Given this list of marker genes WBP2, ICOSLG, CYGB, MARCHF6, ACACA, NBEAL2, AUP1, RRS1-DT, VPS11, STON1, POLR2A, TRIM11, USP40, ZNF746, APLP2, PPP1R9B, BLTP3A, NKTR, SMYD5, ARID5A, CENPT, TENT5A, PDLIM1, WDR31, PHOX2B, WHAMM, GORASP1, YKT6, ARAF (NCBI Gene Id 369), PREX1, LINC00852, DOCK2, ARHGEF28, KRT18, SIK3, ATG2B, SERPINE1, EIF3B, KIAA1614, PRSS58, OR3A1, GP6, OMG, PWWP2B, MRPL45P2, MCHR1, ZER1, ADCY4, TRIM41, MAN2A2, FBXL12, FMNL1, CAPN1, MAPKAPK2, CTSK, HOMER2, TMEM94, AFAP1L2, SMOX, ABL1, KCNAB2, PTPN18, PLEKHS1 (pleckstrin homology domain containing S1), MAN2C1, TSPAN33, PIP5K1C, PARGP1, BMF, SERPINB6, DCTN1, ACCS, ANKRD10, MAP1B, TOE1, SUPT5H, PPP6R1, ZBTB34, NAA15, HGS, VIPR1, SNX29, PCDH11Y, NRDC, ATAD5, RIN3, MAPKAP1 (NCBI Gene Id 79182), ULK1, PJVK, NXF1, ATF4, SMAD7, XPNPEP1, PAN3, SUPV3L1, PCLO, DDX24, RP9, TGFB1, PARP6, ATF5, DCAF1, SLC11A2, NEK3, LEPROT, PNISR, MED27, CCNT1, WDR91, LINC01426, ZNF317, SMG7, PML, IP6K2, PIK3R5, MYO19, DNAJC4, PHLPP1, SQSTM1, ATG9A, TMEM198B, AGPAT1, IBA57, PITPNM1, KMT5A, INF2, RNF103, LDB1, GMEB2, USP5, ALKBH5, LINC02915, BAP1, MDM4, CTNNBIP1, SPNS1, STUB1, ARHGAP4, GARS1-DT, PEDS1, TENT4A, GATA2-AS1, GLTP, TEX36, GRIK1-AS1, UBAP2L, AKAP8, TLE3, CARM1, DIP2B, CUL9, SFPQ (NCBI Gene Id 6421), RPRD1B, MNS1, AP1G1, TPM2, ACTB, SEC31B (SEC31 homolog B, COPII coat complex component), UBE2E3, ZNF185, CORO7, OR2F2, GCNT7, FAM133B, ZNF34, ZXDB, RNF126, MAP4K4, FGD6, ACAP3, TUG1, MAP3K3, C6orf136, MGLL, SMR3B, USP36, FAM238B, SND1-IT1, GABBR1, ENG, PER1, WRN, AJUBA, BMAL1, CYP4F8, SRSF1, SGSH, NAB2, TBC1D5, LINC01089, TNFRSF1B, STXBP2, here is a description of the gene set: Genes up-regulated in comparison of unstimulated peripheral blood mononuclear cells (PBMC) 1 day after stimulation with YF17D vaccine versus PBMC 21 days after the stimulation. Human Gene Set: GSE13485_DAY1_VS_DAY21_YF17D_VACCINE_PBMC_UP The immune responses generated by YF-17D by profiling genes in 25 vaccine recipients were accessed at days 1, 3, 7, and 21 post-vaccination compared to pre-vaccination in PBMCs. The immune responses generated by YF-17D by profiling genes in 25 vaccine recipients were accessed at days 1, 3, 7, and 21 post-vaccination compared to pre-vaccination in PBMCs. from publication Querec TD, Akondy RS, Lee EK, Cao W, Nakaya HI, Teuwen D, Pirani A, Gernert K, Deng J, Marzolf B, Kennedy K, Wu H, Bennouna S, Oluoch H, Miller J, Vencio RZ, Mulligan M, Aderem A, Ahmed R, Pulendran B (PMID 19029902) species: Homo sapiens